Given this list of marker genes AKT3, TMC5, TRPC1, MAL, THEMIS2 (NCBI Gene Id 9473), NR4A3, ZMAT1, NR1H4, LGALS7, MMP7, BHMT, ITGB4, IFI44L, AKAP17A, JAG2, SLC22A1, TF, MED12, GP2, FMNL1, CCL4, CRX, SERPINB3 (NCBI Gene Id 96249), MUCL1, SLC19A1, PLCL1, KLRC2 (NCBI Gene Id 3822), KASH5, TP53, COL13A1, MAP9, CA3, ECM2, ROS1 (NCBI Gene Id 6098), IFT52, ARHGEF28, KCNQ1OT1 (NCBI Gene Id 11111), FBRS (NCBI Gene Id 8734), here is a description of the gene set: Human Gene Set: MODULE_458 Genes in the cancer module 458. studied in species Homo sapiens